Given this list of marker genes Nr5a1, Crebl2, Gdi2, Mga, Adcy1, Hipk3, Acp2, Alx1, Alg10b, Emg1 (NCBI Gene Id 14791), Ccdc92, Aasdhppt, Sf1, Akap11, Oit3, Fbxo42, Avpr2, Ccr4 (C-C motif chemokine receptor 4), Myrf, Snph, Exosc6, Dlg2, Ubqln4, Gpc6, Xaf1, Ugt3a2, Kat7, Map3k9, Rasd2, Arl5b, Rnpepl1, Sh3pxd2b, Myadm, Mtcl2, Tmc2 (NCBI Gene Id 192140), Plpp5, Cuedc1, Spock1, Smagp, Sv2b, Fbxl22, Vipr1, Sdc3, Ttc41, Mr1, Ddx3x, Kpna1, Neu4, Amotl2, Nck2, Slc25a19, Dtx4, Slc48a1, Dennd6b, Glis2, Eif4ebp3, Zfp748 (zinc finger protein 748), Sh3tc2 (NCBI Gene Id 225608), Mtf1, Slc8a3, Ehd2, Fgfr3, Esr1, Erc1, Cdk5, Cfap96, Ebna1bp2, Chrna2, Ptdss2, Mtcl1, Mecp2, Cadm2, Vamp3, Ercc4, Hpgds, Retreg3 (NCBI Gene Id 74428), Dmbt1, Hpcal1, Magohb, Gnao1, Hapstr1, Slurp2, Lrrc55, here is a description of the gene set: studied in species Mus musculus Genes predicted to be targets of miRBase v22 microRNA mmu_miR_7662_3p in miRDB v6.0 with MirTarget v4 prediction scores > 80 (high confidence targets). Mouse Gene Set: MIR_7662_3P from publication Chen Y, Wang X (PMID 31504780)